The following is a description of a gene set: studied in species Mus musculus Mouse Gene Set: XIE_TRASTUZUMAB_CARDIOTOXICITY_MMU_MIR_155_3P_GENES Abstract: Trastuzumab-induced cardiotoxicity (TIC) is a common and serious disease with abnormal cardiac function. Accumulating evidence has indicated certain non-coding RNAs (ncRNAs), functioning as competing endogenous RNAs (ceRNAs), impacting the progression of cardiovascular diseases. Nonetheless, the specific involvement of ncRNA-mediated ceRNA regulatory mechanisms in TIC remains elusive. The present research aims to comprehensively investigate changes in the expressions of all ncRNA using whole-transcriptome RNA sequencing. The sequencing analysis unveiled significant dysregulation, identifying a total of 43 circular RNAs (circRNAs), 270 long noncoding RNAs (lncRNAs), 12 microRNAs (miRNAs), and 4131 mRNAs in trastuzumab-treated mouse hearts. Subsequently, circRNA-based ceRNA networks consisting of 82 nodes and 91 edges, as well as lncRNA-based ceRNA networks comprising 111 nodes and 112 edges, were constructed. Using the CytoNCA plugin, pivotal genes - miR-31-5p and miR-644-5p - were identified within these networks, exhibiting potential relevance in TIC treatment. Additionally, KEGG and GO analyses were conducted to explore the functional pathways associated with the genes within the ceRNA networks. The outcomes of the predicted ceRNAs and bioinformatics analyses elucidated the plausible involvement of ncRNAs in TIC pathogenesis. This insight contributes to a better understanding of underlying mechanisms and aids in identifying promising targets for effective prevention and treatment strategies. from publication Xie S, Zhou N, Su N, Xiao Z, Wei S, Yang Y, Liu J, Li W, Zhang B (PMID 38577019), and this is the list of marker genes: Abr, Dach1, Lrtm1, Kctd12, Wbp1l, Kdm2b, Lemd2, Tia1, Tfrc, Arrb1, Atp2a3, Nr6a1, Tmem201